The following is a description of a gene set: The series of molecular signals initiated by an extracellular ligand binding to a receptor on the surface of the target cell where the receptor possesses guanylyl cyclase activity, and ending with the regulation of a downstream cellular process, e.g. transcription. studied in species Mus musculus Mouse Gene Set: GOBP_RECEPTOR_GUANYLYL_CYCLASE_SIGNALING_PATHWAY, and this is the list of marker genes: Nppb, Gucy2f, Nppc, Gucy2d, Nppa, Npr2, Gucy2g (guanylate cyclase 2g), Npr1, Gucy2c, Gng7, Gucy2e